Given this list of marker genes HVCN1, CATSPER4, CATSPERB, KCNU1, CATSPERG, CATSPER2, CATSPER3, CATSPERD, CATSPER1, here is a description of the gene set: studied in species Homo sapiens Sperm Motility And Taxes Human Gene Set: REACTOME_SPERM_MOTILITY_AND_TAXES